Given this list of marker genes DDIT4, AREG, RGS2, CD44, EIF4A3, HSPD1, SERTAD1, NR4A2, DUSP2, IER2, NFKBIZ, SDCBP, HSPH1, JUN, HSP90AB1, IL7R, PPP1R10, BRD2, P2RY10, TSC22D3, HSPB1, LINC-PINT, VPS37B, FUS, NEU1, CLEC2B, NFE2L2, RSRP1, PPP1R15A, PDE4B, ZFP36L2, DDX24, SRGN, PTGER4, GADD45B, TNFAIP3, PPP1R2, PHLDA1, SAT1, DUSP1 (NCBI Gene Id 1843), SLC2A3 (NCBI Gene Id 94827), CXCR4, NCL, RGS1, USP36, XCL1, LMNA, LDHA, RASGEF1B, CLK1, CALM2 (NCBI Gene Id 805), RALGAPA1, UBC, BTG1, PTMA, CDKN1A, STAT3, PRMT9, RGCC, TENT5C, IVNS1ABP, SRSF7, SELENOK, SNHG15, DNAJB6, VIM, NR4A3, ZFAND5, CREM, ALG13, PRDX1, TAGLN2, FAM177A1, SYAP1, SOCS1, FOSL2, TOB1, PTGES3, KLF6, CDKN1B, PIK3R1, MALAT1, NR4A1, H4C3, JUNB, EIF5, CEMIP2, AHNAK, TSPYL2, DNAJA1, H2AX, JMJD6 (jumonji domain containing 6, arginine demethylase and lysine hydroxylase), MYADM, PNRC1, LEPROTL1, CYCS, PTP4A1, NFKBIA, CRTAM, EIF4A2, CITED2, HSP90AA1, EIF1, SOD1, GTF2B, NABP1, INSIG1 (insulin induced gene 1), SLC38A2, TUBA1A, FTH1, JUND, BTG2, DDX3X, NR3C1, BIRC3, RNF19A, ANXA1 (annexin A1), SQSTM1, FOSB, STK17B, WSB1, CD55, DYNLL1, MCL1, TAGAP, BCAS2, REL (REL proto-oncogene, NF-kB subunit), RPL22L1, TUBA4A, GPR183, SARAF, SNHG12, UBE2B, TUBA1B, H3-3B, ELF1, ZNF331, GABARAPL1, TNFSF9, CD28, RANBP2, HSPA5, ANKRD37, CHMP1B, DNAJB1, CKS2, NIBAN1, ICOS, SAMSN1, CYTIP, KDM6B, CD69, RBKS, EZR, YPEL5, ZFP36 (NCBI Gene Id 7538), GZMK, FOS, HSPA8 (heat shock protein family A (Hsp70) member 8), TUBB4B, EML4, HSPA1B, CCNH, PDCL3, TGIF1, SOCS3, RHOH, IDS, TIPARP, HSPA1A, CSRNP1, HSPE1, CACYBP, UBB, DUSP4, ZFAS1, SRSF2, here is a description of the gene set: Human Gene Set: JIANG_MELANOMA_TRM1_CD8 from publication Jiang C, Chao CC, Li J, Ge X, Shen A, Jucaud V, Cheng C, Shen X (PMID 38455971) Tissue-resident memory T cells (TRM) are a specialized T cell population residing in peripheral tissues. The presence and potential impact of TRM in the tumor immune microenvironment (TIME) remain to be elucidated. Here, we systematically investigated the relationship between TRM and melanoma TIME based on multiple clinical single-cell RNA-seq datasets and developed signatures indicative of TRM infiltration. TRM infiltration is associated with longer overall survival and abundance of T cells, NK cells, M1 macrophages, and memory B cells in the TIME. A 22-gene TRM derived risk score was further developed to effectively classify patients into low- and high-risk categories, distinguishing overall survival and immune activation, particularly in T cell-mediated responses. Altogether, our analysis suggests that TRM abundance is associated with melanoma TIME activation and patient survival, and the TRM-based machine learning model can potentially predict prognosis in melanoma patients. studied in species Homo sapiens